The following is a description of a gene set: A reduced level of prolactin in the blood circulation. Prolactin is a protein hormone that is secreted by lactotrophs in the anterior pituitary and that stimulates mammary gland development and milk production. species: Homo sapiens Reduced circulating prolactin concentration Human Gene Set: HP_REDUCED_CIRCULATING_PROLACTIN_CONCENTRATION, and this is the list of marker genes: PNPLA6, RBM28, IGSF1, NF2, PROP1, TERT, TRHR, AKT1, POU1F1, DBH, SMARCB1, SUFU, HESX1 (NCBI Gene Id 8820), LHX3, PIK3CA, PDGFB, SMARCE1, TRAF7, LHX4, BAP1, SMO, GNAS